Given this list of marker genes Id2, Bcl6, Sfrp1, Hmgb3, Flt3 (FMS-like tyrosine kinase 3), Lilrb4a, here is a description of the gene set: Any process that stops, prevents, or reduces the frequency, rate or extent of B cell differentiation. Mouse Gene Set: GOBP_NEGATIVE_REGULATION_OF_B_CELL_DIFFERENTIATION studied in species Mus musculus